Given this list of marker genes Myh6, Apln, Adra1a, Adrb2, Grk2 (G protein-coupled receptor kinase 2), Cav1, Adm, Nos1, Atp2b4, Gaa, Slc9a1, Prkca, Adra1b, Glrx3, Csrp3, Atp1a2, Adrb1, Nos3, Myl2, Pebp1, Myl4, Ifng, Myh7, Pde5a, Chga, Ryr2, Atp1a1, Pln, Slc8a1, Myl3, Atp2a2, here is a description of the gene set: Any process that modulates the extent of heart contraction, changing the force with which blood is propelled. species: Mus musculus Mouse Gene Set: GOBP_REGULATION_OF_THE_FORCE_OF_HEART_CONTRACTION